Given this list of marker genes H4C2, H4C4, HOXA7, ITPKB, PRDM16, LILRB1, GPR171, C1QC (NCBI Gene Id 90369), CTNNB1, TCTA, ERFE, LTF (lactotransferrin), CLDN18, H4C11, H4C13, RARA, LILRB3, RBM15, H4C8, MAFB, CIB1, YPEL4, PTPN2, GABPA, IL4, H4C16, HOXA9, SKIC8, FBXW7, ZBTB46, APCS, DLL1, CCL3, ZFP36L1, H4C5, LRRC17, TNFRSF11B (TNF receptor superfamily member 11b), ZBTB16, LILRB4, H4C15, HMGB3, HOXA5, INHA, MIR486-1, PAF1, MEIS2, STAT5A, SFRP1, PTK2B, GPR137, UBASH3B, ADIPOQ (adiponectin, C1Q and collagen domain containing), GPR68, HOXB8, H4C3 (NCBI Gene Id 8364), MYB, H4C6, ZFP36, ZFPM1, LDB1, PIAS3, QKI, CTR9, NF1 (NCBI Gene Id 646021), TRIB1, H4C14, CDK6, MIR125B1, LYN, H4C9, RUNX1, LEO1, CEACAM1, MYC, GPR55, ZNF675, TOB2, GPR137B, INHBA, INPP5D (NCBI Gene Id 653796), TNFAIP6, PRMT1, IAPP, CUL4A, H4C12, H4C1, TLR3, CDC73, KLF13, PF4, TLR4 (NCBI Gene Id 7099), STAT5B, HSPA9 (NCBI Gene Id 91471), FBN1, TMEM178A, CALCA, GATA2, MEIS1, TAOK3, FSTL3, CARTPT, PIK3R1, NFKBIA, here is a description of the gene set: species: Homo sapiens Human Gene Set: GOBP_NEGATIVE_REGULATION_OF_MYELOID_CELL_DIFFERENTIATION Any process that stops, prevents, or reduces the frequency, rate or extent of myeloid cell differentiation.